Given this list of marker genes Fastkd2, Pde12, Fastkd1, Fastkd5 (FAST kinase domains 5), Fastk, Fastkd3, Tbrg4, here is a description of the gene set: species: Mus musculus Mouse Gene Set: GOBP_REGULATION_OF_MITOCHONDRIAL_MRNA_STABILITY Any process that modulates the propensity of mitochondrial mRNA molecules to degradation. Includes processes that both stabilize and destabilize mitochondrial mRNAs.